Given this list of marker genes RPL11, RPL27A, EPRS1, RPS3A, PNN, RPS19, RPL36A, ATP5MC3, NDUFA12, UBA52, EEF1G, RPS28, CLIC1, RPL29, CSNK2B, RPL19, NAP1L1, RPL6, SNRPD3, RPL7A, UBE2L3 (NCBI Gene Id 7332), APEX1, TCP1, PSMA2, NCL, IK, RPS5, TIAL1, HINT1, HNRNPU, RPL31, RPS6, SLC25A6, POLR2G, PSMA1, SNRPE, RPL35A, NASP, RPL17, UQCRH, RPL10A, RPL34, RPS3, TBCB, HNRNPM, RPL18, RPL35, RPS24 (NCBI Gene Id 6229), COL16A1, RPS18, RPL7, EEF1B2, RACK1, SUMO2, CLEC18C, HNRNPA1, POLG, NONO, ZNHIT3, EEF2, SAP18, RPS16, ATP5F1B, KHDRBS1, RPS11 (ribosomal protein S11), SET, RPSA, TRIM28 (NCBI Gene Id 96054), FXR1, RPL3, RPS27A, RPL27, ILF2, RPS9, RPL21 (ribosomal protein L21), TPT1, SLC25A3, NPM1, PTMA, ACTG1, PSMA5, RPL32, HSP90AB1, H2AZ1, PWP1, RABGGTB, SRSF9, SNRPF, RPS2, PSMB4, NACA, RPL14, RPS7, RPS23, SNRPA1, EIF4B, TAF9, PSME1, RPL4, RPS8, RPL23, RPL28, PPP1CC, RPS14, RPL13A, PRMT1, EIF3F, HNRNPH1, H3-3A, RPL9, SNRPD2, ESD, APRT, PPIA, ATP5PB, DUT, here is a description of the gene set: Neighborhood of NPM1 Neighborhood of NPM1 nucleophosmin (nucleolar phosphoprotein B23, numatrin) in the GCM expression compendium Human Gene Set: GCM_NPM1 studied in species Homo sapiens